The following is a description of a gene set: species: Homo sapiens The directed movement of ornithine, 2,5-diaminopentanoic acid, into, out of or within a cell, or between cells, by means of some agent such as a transporter or pore. Human Gene Set: GOBP_ORNITHINE_TRANSPORT, and this is the list of marker genes: SLC7A2, SLC25A29, SLC7A3, SLC25A15, SLC7A1, SLC7A6, SLC25A2